The following is a description of a gene set: Human Gene Set: GOBP_GAMMA_AMINOBUTYRIC_ACID_SIGNALING_PATHWAY species: Homo sapiens The series of molecular signals generated by the binding of gamma-aminobutyric acid (GABA, 4-aminobutyrate), an amino acid which acts as a neurotransmitter in some organisms, to its receptor on the surface of a target cell., and this is the list of marker genes: HTR1A, GABRG2, GABRB3, SHISA7, GABBR2 (NCBI Gene Id 9568), GABRE, GABRR3, PIANP, GABRA4, ATF4, GABRA2, GABRR1, GNAI2, GABRB1, GABRB2, PLCL2, GABRG1, GABRA1, GABRA3, GPR156, GABRA6, GABBR1, GABRG3, SLC12A2, GABRD, CACNB4, PHF24, GABRA5, PLCL1, GABRR2